The following is a description of a gene set: Human Gene Set: DESCARTES_MAIN_FETAL_SCHWANN_CELLS Marker genes curated from the annotated cluster as represented in the Descartes Human Gene Expression During Development database. from publication Cao J, O'Day DR, Pliner HA, Kingsley PD, Deng M, Daza RM, Zager MA, Aldinger KA, Blecher-Gonen R, Zhang F, Spielmann M, Palis J, Doherty D, Steemers FJ, Glass IA, Trapnell C, Shendure J (PMID 33184181) studied in species Homo sapiens The gene expression program underlying the specification of human cell types is of fundamental interest. The study authors generated human cell atlases of gene expression and chromatin accessibility in fetal tissues. For gene expression, the study authors applied three-level combinatorial indexing to >110 samples representing 15 organs, ultimately profiling ~4 million single cells. The study authors leveraged the literature and other atlases to identify and annotate hundreds of cell types and subtypes, both within and across tissues. Our analyses focused on organ-specific specializations of broadly distributed cell types (such as blood, endothelial, and epithelial), sites of fetal erythropoiesis (which notably included the adrenal gland), and integration with mouse developmental atlases (such as conserved specification of blood cells). These data represent a rich resource for the exploration of in vivo human gene expression in diverse tissues and cell types., and this is the list of marker genes: PMP22 (NCBI Gene Id 5376), ITIH6, C1orf198, LGI1, BMP8B, PLP1, DHH, TSPAN11, NGFR-AS1, EXTL1, SOX10, KIAA1755, MIA, RHBDF1, DUTP6, TMEM176A, OLFML2A, AQP7P1, COL28A1, STARD13, ASPA, EDNRB, GPR83, SCN7A, CHL1-AS2, FOXD3, CTF2P, ABCA8, CADM4, MRGPRF-AS1, C12orf76, TECTB, GFRA3, LINC01608, ENTPD2, HSPD1P4, ADAM23, MPZ, LINC00466, NGFR, CNP (NCBI Gene Id 1267), ANGPTL7, PLAT, S100B, LINC01505, GAS2L3, GJC3, PRNP, NANOGP1, LINC00327, SEMA3G